The following is a description of a gene set: Human Gene Set: GOBP_REGULATION_OF_RESPONSE_TO_WOUNDING Any process that modulates the frequency, rate or extent of response to wounding. studied in species Homo sapiens, and this is the list of marker genes: TNF, TNR, CLDN3, TNFAIP3, FIGNL2, TNFRSF12A, EDN1, BRAF, DDR2, CNTF, DUOX1 (dual oxidase 1), PRKG1, CLDN1, TAFA5, EPHB2, FGB, IL33, TMEM97, PTEN, CERS2, RTCA, KLF4, PTK2, EXTL3, APOE, F2RL1, INPP5F, FOXA2, SRSF6, SPP1, CLASP1, SERPINB2, ANXA2, SERPING1, MTOR, MMRN1, CASK, HMGB1, APCS, VTN, CADM4, DMTN, CD9, CAV1, HBEGF, HPSE, PDGFA (platelet derived growth factor subunit A), F2R, NOS3, ACTG1, F7, PLAUR, PROC, ALOX5, PRDX2, TBXA2R (NCBI Gene Id 6915), F2, FAP, VIL1, EPPK1 (NCBI Gene Id 83481), KANK1, IL17A, FERMT1, MIR222, OCLN, PTPN6, PHLDB2, FERMT2, PROS1, ADAM17, F3, FOXC2, HTN1, SERPINC1, KNG1, WNT4, DSG2, REG3G, CLDN4, CRK, MAP2K1, F11, MIR431, C1QTNF1, TFPI, EMILIN2, PDGFRA, PTN, ANXA1, HTN3 (NCBI Gene Id 3347), FGA, THBD, STK24, AJAP1, ANO6, HRAS, MIR34A, MIR29A, APOH, MYLK, NTRK3, ALOX12, HRG, MIR451A, PRKCD, TMX1, LRIG2, ST3GAL4, ADTRP (NCBI Gene Id 84830), ITGB1, PUM2, MDK, DUOX2, PRKCE, SMAD3, MIR1298, GIT1, MIR200B, RTN4R, KREMEN1, IL10, WFDC1, CLEC7A, SMOC2, SLC12A2, GRN, PLAT, THBS1, SERPINF2, REG3A, USF1, SERPINE1, ARFGEF1, PDGFB, MIR21, VEGFB, SERPINE2, FGF2, CPB2, INSL3, FGG, PTPRF, RREB1, SIGLEC10, PLG, PF4, ADRA2A, MAP2K2, PLAU, NEO1, NFE2L2, STAT3, TSPAN8, KLKB1, CEACAM1, MIR15B, F12, KIAA0319, XBP1, RGMA, SH2B3, KRT1, CCN4, PTPRS, SCARF1 (NCBI Gene Id 8578), MYOZ1, GP1BA, ENPP4 (NCBI Gene Id 57011), RTN4RL1, CD109, MIR221, EPHA4, CD36 (CD36 molecule (CD36 blood group)), ADAMTS18, EMILIN1, CLASP2, UBASH3B